The following is a description of a gene set: Mouse Gene Set: REACTOME_INTERLEUKIN_36_PATHWAY Interleukin-36 pathway species: Mus musculus, and this is the list of marker genes: Il1rl2, Il1f10, Il36g, Il1rap (interleukin 1 receptor accessory protein), Il36rn, Il36a, Il36b